The following is a description of a gene set: from publication van Gurp L, Fodoulian L, Oropeza D, Furuyama K, Bru-Tari E, Vu AN, Kaddis JS, Rodríguez I, Thorel F, Herrera PL (PMID 35440614) Single cell RNAseq data from human pancreatic islets was downloaded from 7 previously published datasets. Pairwise differential expression was calculated between all islet cell types in each dataset, and results were integrated to compose a core list of ID genes for each cell types, organised primarily on the number of analyses a gene was detected in. A machine-learning based approach was used to threshold which genes were included in the final ID geneses, and these genesets were then cross validated in three independent datasets to demonstrate they outperformed previously published lists of ID genes. Human Gene Set: VANGURP_PANCREATIC_ALPHA_CELL Transcriptomic signature geneset for human pancreatic alpha cells derived from meta-analyzing multiple single cell RNAseq datasets studied in species Homo sapiens, and this is the list of marker genes: CRYBA2, CYSTM1, GC, NAA20, MUC13, HLA-A, SMIM24, PCSK2, TMEM176A, PALLD, CFC1, LOXL4, B2M, HLA-E, GPX3, F10, TTR, IRX2, FXYD5, PLCE1, PLIN3, FAP, CLU, TM4SF4, TMEM176B, ITGB1, GLS, RNASEK, PAPPA2, SLC7A2, DPP4, FXYD3, PEMT, HIGD1A, ALDH1A1, VGF, SPINT2, RGS4, KCTD12, GCG (glucagon)